The following is a description of a gene set: Human Gene Set: GSE19941_IL10_KO_VS_IL10_KO_AND_NFKBP50_KO_LPS_STIM_MACROPHAGE_UP studied in species Homo sapiens Genes up-regulated in macrophages stimulated by LPS: IL10 knockout versus IL10 and NFKB1 knockout. from publication Yang HT, Wang Y, Zhao X, Demissie E, Papoutsopoulou S, Mambole A, O'Garra A, Tomczak MF, Erdman SE, Fox JG, Ley SC, Horwitz BH (PMID 21217011) Bone marrow-derived macrophages were produced from mice lacking IL-10 alone (IL10-def) or mice lacking both IL-10 and the p50/p105 subunit of NF-kB (p50/IL10), and left unstimulated, stimulated with LPS (1 ng/ml) or stimulated with LPS and IL-10 (0.3 ng/ml)., and this is the list of marker genes: DALRD3, SLC26A10P, IDO2, FAAH, PSMB7, TOMM7, HSD17B11, DYNLRB2, CFAP410, LGALS7, SLCO3A1, PARP14, MMUT, GCLM, EFHD2, SIVA1, IL18, MORN4, TRIM5, SAA4, P2RX6, RALBP1, CASP3, TMEM54, C1orf35, ELL3, SPATA46, CCL5, KCNB1, CXCL12, CD200, IGF2, PDCD1, TMEM216, PCMT1, GRAMD1B, NME5, IL2, HIC1, S100A5, PLA2G4A, PTP4A2, CAPZB, FRK, ZNF560, CDC73, GABARAPL2 (GABA type A receptor associated protein like 2), OXSM, PAX4 (NCBI Gene Id 5078), CAVIN2, AP1S3, GRM4, ETFB, FAM181B, BRD8, THOP1, COMMD2, RAC2, CDH9, AGA, ARC, EMC2, CHRM4, CDH1, TLE5, UMODL1, PROM1, GARIN3, GPR75, ZCCHC17, MAGT1, SLC34A2, MICOS10 (mitochondrial contact site and cristae organizing system subunit 10), RASSF7, HDC, PLCD4, NQO2, EYA2, ATP5PO, ZMYM1, TRIM54, ATP6V1C1, PIGT, SHFL, TRAPPC2L, VAT1L, SYT12, DYNLT2B, SLAMF6 (NCBI Gene Id 114836), UGGT2, PAICS, MRPL34, LYPD6B, OR52A1, ERCC1, MLKL, CWC15, MIA, PSMA6, HSPE1, CALCRL, HLX, MST1, COX7A2 (cytochrome c oxidase subunit 7A2), TTC12, GDF15, TDRD1, SERPINF1, FST, TSFM, MYCBPAP, IL1RL2 (interleukin 1 receptor like 2), PLA2G5, EMX1, LDB2, TRIM14, TAF11, ABHD1, DCN, ENTPD7, NSUN3, GMPR2, C19orf53, RTN4IP1, COX6C, HRH4, TCHHL1 (NCBI Gene Id 126637), LRRC8D, HAGH, PLEKHJ1, TRIAP1, FAM117A, RSPO2, ISCU, DPH3, MYL1, CLPB, HTR5A, PTRHD1, IL18RAP (interleukin 18 receptor accessory protein), HK3, CFAP251, SERPINE2, TMPRSS6 (transmembrane serine protease 6), LYG2, TRIM34, TRMT11, SNX9, MCU, AP2M1, ATOX1, TBX21, PEDS1, PSME2, ZNF697, RYBP, FH, SAP30BP (NCBI Gene Id 29115), MBNL1, VWA8, TSPAN12, MINPP1, IFITM3, GGH, GIPC2, ADAM8, SERPINC1, RBM14, CNTN3, BRI3BP, RYR2, GATA3, EIF1AX, MED30, KRTAP3-3, MALSU1, SETDB2, ASTE1, BMP8A (NCBI Gene Id 79787), MOXD1, TBC1D2, PPP1R1A, MGAM, ARPC4, SMARCA1, B3GALT1, IRAG2, IPCEF1, FNDC9, CERKL, SRRD, PUS10, VCF1, ATG3, TMEM229B, TAP2, LRRTM1, LEF1, EPS8L3, TMEM102